Given this list of marker genes Zfp1005 (zinc finger protein 1005), Oma1, A830018L16Rik, Tasor, Gm1553, Samd11, Msl2, Hcrtr2, Fez2, Nr2f6, Lpar6, Hnrnpr, Sema6a, Fbxw7, Recql, U2surp, Gm14391, Ncoa2, Cnst, Ube2d2a, Adgre4, Pik3cb, Gclc, Srp54b, Sntg1, Spag16, Wtap, Hecw2, Gucy2c, Tbc1d19, Clip1, Lamc1, Trappc2b, Rraga, Rundc1, Ddah1, 9130008F23Rik, Pgap1, Wdr27, Stam, Pccb, Tmem216, Etfdh, Slc17a5, Chd9 (NCBI Gene Id 77692), Adgrl2, Got1, Cycs, Prkcb, Creb1, Cox18, Zfp869, Enpp1, Cdon, Rora, Zfp40, Zfy1, Loricrin, Xpnpep2, Nmt2, Fam91a1, Sowahd, Leprot, Gm6710, Cep170, Tnrc6c, Kcnv1, Zfp345, Kdm3b, Jak2, Arl13b, Kng1, Epha7, Zfp781b, Spmip4, Ppp3ca, Cdk17, Pum2, Eny2, Rfx7, Kdm1b, Naa40, Sesn3, Ano5, Cenpj, Ccdc138, Tdrd5, Mmd, Osbpl3, Zc3h6 (NCBI Gene Id 99301), Mapk8, Cep135, Paip1, Clint1, Gm14325, Rsbn1, Ttc13, Scoc, Lrrtm2, Top1 (topoisomerase (DNA) I), Tia1, Gm5431, Prdm8, St3gal2, Slc17a3, Spag9, Gm2026, Mrm2, Actr3, Snx11, Azin1, Slc5a8, Fermt2, Styx, Med1, Zfp971, Gm14326, Idi2, here is a description of the gene set: from publication Chen Y, Wang X (PMID 31504780) species: Mus musculus Genes predicted to be targets of miRBase v22 microRNA mmu_miR_433_3p in miRDB v6.0 with MirTarget v4 prediction scores > 80 (high confidence targets). Mouse Gene Set: MIR_433_3P